The following is a description of a gene set: Human Gene Set: GOBP_REGULATION_OF_ODONTOGENESIS species: Homo sapiens Any process that modulates the frequency, rate or extent of the formation and development of a tooth or teeth., and this is the list of marker genes: BMP4, BMP2, TGFB1, CD34, RSPO2, FGF8, EDN1, SP6, DMRT3, CSF1, NGFR, TNFRSF11B, SHH, PAX9, WNT10A, MSX1, RUNX2, APCDD1